Given this list of marker genes TMEM187, PPCDC, DARS1, HOMER2, FPGS (folylpolyglutamate synthase), SENP7, GRK6, MCM4, PTPN9, RPL12, SOX14, ZNF536, FBLN5, RBP4, DOCK9, BSCL2, ADAMTS3, TTLL1 (TTL family tubulin polyglutamylase complex subunit L1, NCBI Gene Id 25809), FOXA1, TUBA1C, RNASEH2A (NCBI Gene Id 10535), LINC00302, MYLK3, RPL18, FARS2 (NCBI Gene Id 10667), HIGD2A, CDC25B, PKIG, GMIP, SPO11 (NCBI Gene Id 23626), IGLV4-60 (immunoglobulin lambda variable 4-60), FAM193B, ATP5MF, CDK18, IK, RPS3A, S100A4, CENPM, HSF1, SERPINA5, NR0B1, GATA4, RPL35, GLB1, CCR4, GORASP1, TNPO2, CD27, CCDC28B, H3C8, NME4, TEX41, MOG, NUP62CL, ID4, LHPP, CD83, SLC6A16, RND3, TESK1, LYRM9, TBCD, PMS2P2, DKK3, IFIT1, TRAF2, STAT5B, PGAP3, DHODH, LAMTOR2, MTCP1, SCUBE3, SRD5A1, ZNF195, SRGN, BCL2L11, CBX5, LRFN3, GSTA4, CENPN, PPIH, SAE1, MTMR14, VIM, APOBR, NT5E, CAB39L, ZSCAN18, OR2W1, GNAT3, IL9R, ASH2L, HOOK1, TNK2 (NCBI Gene Id 10188), FOXM1, SSTR1, SMIM14, LRP12, ARRB1, MTRF1L (mitochondrial translation release factor 1 like), IL4R, SLC38A6, GDF10, ADGRE1, BCL2L1, TAF12 (TATA-box binding protein associated factor 12), GRTP1, AATF, CRELD1, MAD1L1, SELPLG (NCBI Gene Id 6404), VPS13D, SNCA, EPHX2, GUK1, ACTR2, MACF1, CORO2A, MT1M, CALM3, TNC, POLR2G, ACAA1, IGFLR1, LINC00474, STAT4, H2AC14, PRPH2, MYL6, LY86, RPS17, LHX6, RPL41, IL16, MCRS1, RPS27L, MYOM2, SPINT2, HSD17B3, WASL, SPTAN1, MBTD1, SMG6, HSD11B2, ACAA2, IMPA2, MAP7, CRIP1, ZNF154, OR2J2, CAV1, HES1, NPIPA1, CD52, UGT2B4, POLM, CNNM3, PDCD1LG2, IFT20, CBARP, LST1, ID3, FAM50B, DNMT3B, NFIC, VAX2, RBM15B, RING1, RRAD, POLR2L, RLN2, AKR1A1, EVL, THEMIS2, TCF20, HCFC1, BBS9, MYO9B, COTL1, PDLIM2, ZNF423, PFDN5, SDHA, FLT3LG (fms related receptor tyrosine kinase 3 ligand), CUL9, GPX4, SSUH2, ABCA7, CPPED1, KIF22, BIN3, HIPK2, HCLS1, KIAA0087, IGBP1, GSDMD, ZNF394, MIIP, ACTR3B, here is a description of the gene set: species: Homo sapiens Human Gene Set: GSE2585_THYMIC_DC_VS_THYMIC_MACROPHAGE_DN Gene expression in different thymic stromal cells and subsets thereof was analyzed in 6-12 week old wild type (C57BL/6) and Aire knock-out (mixed background) mice. Thymic stromal cells were purified by sequential enzymatic digestion (collagenase, collagenase/dispase and trypsin) followed by gradient centrifugation and FACS sorting. Sort criteria were as follows: dendritic cells (CD11c+, F4/80 -), macrophages (F4/80+, CD11c-), cTECs (CD45–/lo, CDR1/Ly51+, Ep-CAM+) and mTECs (CD45–/lo, CDR1/Ly51–, Ep-CAM+). mTECs of wild-type and Aire knock-out mice were further subdivided according to CD80 expression levels. For microarray analysis total RNA from thymic stromal cell samples of two independent experiments was pre-amplified and biotinylated by two rounds of cDNA synthesis and in vitro transcription. Fluorescence readings were evaluated by using Microarray Suite 5.0 software. Genes down-regulated in thymic: dendritic cells versus macrophages. from publication Derbinski J, Gäbler J, Brors B, Tierling S, Jonnakuty S, Hergenhahn M, Peltonen L, Walter J, Kyewski B (PMID 15983066)